Given this list of marker genes APOC2, DPP4, PDCD1LG2, DAPL1, IL10RA, PRICKLE2, SH3RF3, SERPINB9, MMP1, SATB2, WFDC21P, ADAMTS12, PDPN, CSMD1, GLT8D2, INHBA, CDKN1A, MEIS3, C1orf162, TCIM, DLC1, FILIP1L, CSF3R, APOC1, KLHL6 (kelch like family member 6), IGHV5-51, CHN2, PRELP, DIO2, C2CD4B (NCBI Gene Id 388125), NRROS, CPED1, SERPINE1, FPR1, LCP2, SDS (NCBI Gene Id 10993), ENOX1, ZFP36, NRP1, HLA-DQA2, AMIGO2, BTK, PDE1A, MEDAG, CD300E, MGP, C11orf96, CASP1, GALNT5, OLFM4, ABCA8, HTR2B, EPHA3, IGHG4, C5AR1, GATA6, MAGI2-AS3, SMOC2 (NCBI Gene Id 64094), AFF3, CD302, ACVRL1, AXL, HNMT, PALLD, DPYD, SAA2-SAA4, PTPRN2, CALD1 (NCBI Gene Id 800), PMP22 (NCBI Gene Id 5376), FAM13C, CXCR6, TRABD2A, PLAUR, CCL20 (NCBI Gene Id 6364), SCN9A, PIK3CG, VCAM1, VSIG4, TNFAIP8, KYNU, HOPX, DCLK1, GIMAP1, EEF1B2P6, TRPV2, NLRC4 (NLR family CARD domain containing 4), CCL2, NOD2, LAPTM5, CYP1B1, ADAMDEC1, ICAM4-AS1, TSHZ2, SBSPON, WNT5B, IGFBP7, ANPEP, IGLV1-40, IGHV3-48, SULF1, ZFHX4, HHIPL1, LGALS9, BTN3A3, COLEC12, SCARF1, FOXF2, SMIM3, EPS8, IGLJ2, CYTH4 (NCBI Gene Id 29776), EPSTI1, ITGA2, NAAA, RPL18AP3, EPYC, IGKV3-20, ESAM, IL6, CYP7B1, PSMB9, PTPN7, FBXO32, PLA2G4C, IGHV4-59, C1QA, KIF17, FLI1 (Fli-1 proto-oncogene, ETS transcription factor), RGS16, GGT5, ANKRD44, IGLV1-44 (immunoglobulin lambda variable 1-44), FCGR2A, STAB1, RHOBTB3, FST, SLFN11, DCHS2, SLC31A2, COL14A1, ABCC3, ARHGAP24, LST1, PPP2R2C, ARHGAP18, IGKV1-16, CORO1A, HTRA3 (HtrA serine peptidase 3), RGS1, ANKRD22, SLITRK2, HCST, ITGBL1, CLEC2B, SYPL2, GABRB3, ATP10D (ATPase phospholipid transporting 10D (putative)), PAPSS2, CLIC2, TPSAB1, IL18, HCK, TIPARP (NCBI Gene Id 25976), CERKL, CCN4, CPE, CLIC4, CTSL, PAIP1P2, COL5A1, RAB3IL1, CX3CR1, CA2, APCDD1, LYVE1, VNN2, VSTM4, LRRC8C, MS4A7, ELL2, RPS3AP6, NUDT10, SQOR, PHLDA1, KANK3, IGKJ2, IL2RA, COX7A1, LSP1, PTPN22, VWC2, TENM3, OSMR (NCBI Gene Id 9180), TMEM273, DCHS1, CELF2, EIF5A2, PDE2A, ENAM (NCBI Gene Id 200), SELENOM, ELFN1, ACTA2, ENPP1, IGLV3-10, RIMBP2, SIGLEC9, IL2RG, PLEKHO2, CD200, MCC, PDE4B, RAC1P2, MFAP4, ARL15, HLA-DPB1, FAM83B, TIE1, RPL15P3, MN1, NR4A3 (NCBI Gene Id 8013), GPR132, GIMAP7, NCF4, LRRK2, HMOX1, HOXC6, TNFAIP3, PIEZO2 (NCBI Gene Id 63896), ADH1B (alcohol dehydrogenase 1B (class I), beta polypeptide), FN1, SPRED1 (sprouty related EVH1 domain containing 1), APOC4-APOC2, SPATA18, MEG3, CYTOR, ABI3BP, TMOD2, CD93, HSPA7, IGHG1, CSTA, COL1A2, TSPAN8, CLDN5, COL8A1, TAGAP, GPRASP1, LRRC32, COL6A3, PLS3, MOXD1, TDO2, TMEM86A (NCBI Gene Id 144110), DPP7, ADGRA2, CFI, TLR8, BIN2, CCR2, GPR65, ETV1, PCYT1B, BCL6B, PLPP4, EPAS1, CXCL13, FKBP14, GRK3, PDLIM5, SLC18A2, HLA-J, FABP4, DPYSL3, IGLJ1, PPP3CC, CPNE5, PAG1, FAM81B, PLAGL1, SLC11A1, PPM1L, P2RY1 (NCBI Gene Id 90963), STOM (NCBI Gene Id 2040), ADGRB3, CAV1, TCF4, EMILIN2, FIBIN, CST7, B3GNT9, CXCL10, CRISPLD2, SLC24A3, SERPINE2, JAK3, CISH, TIMP1, SASH3, SLITRK5, HOXC12, SHE, KCTD12, PDGFRL, ERG, GAS6-AS1, SCARF2, COL6A2, COMP, IGLV1-47, VCAN, SKAP2, HMCN1 (hemicentin 1), HLA-DPB2, DTNA, SLC40A1, TNFRSF8, ALPK2, TIMP3, CCDC69, RRAS, NIPAL2, RHOH, FPR3, LRRN4CL (LRRN4 C-terminal like), CYRIA, CD163L1, HLA-DRA, ARHGAP9, GPNMB, ELOVL4, SCN1B, SYNE1 (NCBI Gene Id 85448), PAMR1 (NCBI Gene Id 25891), COL4A2-AS1, DOCK2, THBD, SNRPA1-DT, TMEM215, PEAR1, IGHV2-26, CSMD2, SERPINI1, SATB1, SPON2 (spondin 2), TIGIT, SLC1A1, BEND4, JUNB, PLOD2, RHOJ, COL5A2, SPARC, SLC2A5 (solute carrier family 2 member 5), HLA-DQB1-AS1, IL32, TACC1, RUNX2, EMCN, SIRPB1, IRAG1, IRS1, CDC42EP5, PDE10A (phosphodiesterase 10A), ELN-AS1, LYSMD2, IGHV1-24, FYB1, HLA-K, HBEGF, NTM, GREM1, RARRES1, GUCY1A1, PI15, CYBB, ADAMTS2, MRAP2, MLKL, CCDC80, CRACR2A, TREM2, SAMD5, DUSP1, DKK2, SEPTIN7P3, AKR1C3, TBX3, THY1, HCG4B, MCTP1, NID2, PLA2G7, ELMO1, ADAM12, CD44, S100A8, NAP1L3, MIAT, PCOLCE-AS1, FXYD5, MEIS2, GTSF1, EBI3, FRMD6, CAVIN3, GSTM5, LAMP5, DIPK2B, CACNA2D4, VSNL1, UBD, HLA-DMA, IGSF6, PEG3, ST8SIA4, FCN1, KCNA5, SFRP4, CD300A, C8orf88, GPR84-AS1, ROBO2 (NCBI Gene Id 90370), IKZF1, STAMBPL1, CFB, IGLV3-21, CIMAP1B, OLFML2B, MMP9, PTN, HLA-DRB5, DERL3, LAG3 (lymphocyte activating 3), SFRP1, ACTG2, ADAMTS7, IGLV2-14, SLC16A6, HOXA-AS2, FTLP3, STX11, IGKV1-9, RTN4RL2, NECAB1, NPTX2, HLA-DQB1, OLFM1, TNFRSF11A, SERPINF1, LOXL2, RASGRP3, CD180, SLC16A14, PRDM6, GPR137B, RPL9P7, STARD8, MATN3, CACNA1H, C2CD4C, LAMA2, SAA2, P2RX7, JAZF1, FGD2, PELATON, DACT1, DPYSL4, CDH13 (cadherin 13), SNCA, GZMK, MT1G, JCAD, ITGA5, KCNA6, NLRP3, COL5A3, HEYL, IGHG3, GIMAP8, SNX20, VIT, CD248, CLIC6, STARD5, FLT3LG, PLCXD3, DOCK10, SRPX2, MMP2 (NCBI Gene Id 4313), LILRB4, NDN, HLA-DMB, SLC7A7, RARRES2, PLSCR4, DCN, CXCL8, CARD16, PRRX1, TBX18 (NCBI Gene Id 9096), ABCA9, IGHV3-53, SECTM1, GALNT15, FCGR3A (NCBI Gene Id 2214), GNG11, PLAT, CCDC85A, RPL10P16 (ribosomal protein L10 pseudogene 16), IL4R, ALOX5, FGR, FERMT3, CD8A, HSPA12B (heat shock protein family A (Hsp70) member 12B), FGL2, PTPRB, IL15, MAP1B, TMEM150C, LINC00511, CR1, C2, MFNG (NCBI Gene Id 4242), ADAM8 (NCBI Gene Id 101), COL6A1, PTPRC, MICU3, IGHV4-39, FOXL1, RPL3P4, ACKR1, MYO1G, STK17B, SYCE1, CBLN2, IGKJ5, RPL5P1, MRC2, GDF6, PAPPA, CNRIP1, IL18R1, PDLIM3, COL3A1, IGLV3-25, DOCK4, HLA-DQB2, LIPA, SPOCK1, SERPINA1 (serpin family A member 1), SAT1, NEFH, MSC-AS1, NRXN2, GRAP, IL1RN, CHST7, ALKAL2, ADAMTSL2, LINC01018, LACC1, CCBE1, RPL17P7, LDAF1, MMP11, CTSS, CYS1, RPL39P3, RAMP3, SDC2, JAK2, EDN3, ASPN, CAVIN2, MPP1 (NCBI Gene Id 4354), FOXF1, OSBPL6, ARHGEF6, IGHGP, HAVCR2, MFRP, DGKI, FLRT2, TIMP2, MT2A, UPP1, SLC16A7, SIGLEC7, RPS3AP26, ERAP2, SLC12A5-AS1, GALNT18 (polypeptide N-acetylgalactosaminyltransferase 18), CXCL9, SRGN, LRRC25, RPL26P36, CILP, SPHK1, NKX3-1, CNTN4, DOK2, PLXDC1, ARHGAP10, PTGDS, PPP2R2B, SGK1, PYCARD-AS1, GHR, HLA-H, OSM, CHRNA1, IGHV3-7, FCGR2C, FMO2, ARHGAP25, VCAN-AS1, LRP1, MTUS1, ANTXR2, ST3GAL5, ARHGEF15, SLC37A2, RPL13AP5 (NCBI Gene Id 728658), CLEC11A, FAP, CMAHP, IGFBP4, IRF1, CPNE8, PSD3, TARID, HLA-DRB6, RBP7, RASSF2, ALOX5AP, CASC15, CD247, DPYSL2, NT5E, CD163, LXN, NCKAP1L, NR5A2, CSGALNACT1, TPST2, ATP8A2, VAMP5, SERPINA3, NLRP1, IFIT2, TSHZ3, PRDM1, CXCL14, CAVIN1, GASK1B, FBXL7, CH25H, NLRC5, ENG, SLC43A1, DPT, LHX9, EDA2R (NCBI Gene Id 60401), ANXA6, APOE, RASAL3, NNMT, THSD7A, RORA, PLEK, LRRC15, ITPR2, OLFML3, CCL19, NCF2, NR3C1, STARD13, PRKD1, RHOB, PLA2R1, COL1A1, GATA4, ADM (adrenomedullin), ENPP2, FTH1P10, PLVAP, CARD6, ABLIM3, MSRB3, GUCY1A2, SUCNR1, NR1H4, LDLRAD4, SOX18, PHLDB2, NRK, MPEG1, GPSM3, GSPT2, TNFRSF4, TCF21, TBX15, LUM, CD209, MZB1, IGKV3D-15, C4B-AS1, DNAJB4, CD14, CHIT1, HEPH, JAML, PRF1, IFI30, PLA2G2D, HLA-F, IL33, SIRPB2, LOXL2-AS1, UBE2QL1, KCNJ2, NRP2, C1QTNF7, TRPS1, SLIT2, ACSL5, KCNMB1, POSTN, NDNF, GNB4, WDFY4, CMKLR2, HLA-DRB1, RPS13P2 (NCBI Gene Id 91505), ITGB2 (integrin subunit beta 2), DHRS3, MXRA8, MS4A4A, TRIM47, EDNRA, FAT4, PIK3R5, HIC1, GRK5, CXCL1, CASS4, NFASC (neurofascin), SH3BGRL, CASP10, SELENOP, RPL7AP6, ASTN1 (astrotactin 1), MNDA, FEZ1, LPXN, TNFRSF9, AK5, WSCD1, PLD1, S1PR1, HAS2, ITGAL, SELL, SLPI, RAB8B, ARHGAP31, NUDT11, HYCC1, CEACAM7, CLEC4A, DHRS9, ADGRF5 (adhesion G protein-coupled receptor F5), PIK3AP1, C3, PDGFRB, PTPN5, TNFRSF1B, IGHV1-2, MAP1LC3A, ITGA11, PRRG3 (proline rich and Gla domain 3), CADPS, SLITRK4, GSDMC, LYZ, GBP2, MMP19, FCER1G, IRF8, KCND3, PON3, PDZD4, CCN1, GPR78, SIGLEC1, LIN7A, RCAN2, PLA2G2A, CXCL17, RTN1 (NCBI Gene Id 8108), ARHGAP20, BMP6, PPP1R2P4, SVEP1, KLHDC7B, ACP5, GPC6, B2M (NCBI Gene Id 567), PDZRN4, CXCL2, PARM1, HS3ST3B1, ACAN, DYNLT3, CD48, RERG, WNT5A (Wnt family member 5A), IGHA2, MEF2C, MEGF10, TM6SF1, MARCHF3, MT-TM, SCN7A, PRDM8, CXCL12, PRKCB, TREM1, RAMP1, MIR100HG, PROCR, F2R, LILRB2, ARRDC3, P2RY8, FSTL1, CNTN1, NALF1, SIRPA, SERPING1, EPB41L3, OGN, HLA-B, KCNS3, EGR2, CD68, NME5, IGKJ4, APOD, CSF1R, SLC1A6, RBPMS-AS1, KLF2, TNFAIP8L3, SFXN3, ODAD2, F5, IGKV1-5, DOCK8, RAB6C, HS3ST3A1, IGKJ3, APLNR, SOCS3, PRCD, HLX, PLCL1, RPL21P16, APOL1, GPM6A, ANGPTL2, BGN, PLAU, BEND6 (BEN domain containing 6), ERO1B, BTBD19, RGCC, TNFSF8, KCND2, C1QC, ALDH1A3-AS1, THSD1, PSTPIP1, SSTR1, BCHE, CCND2, FGF13, LGALS1, FTH1P2, TBC1D4, PRSS35, FAS, TNFAIP6, ECM2, DOK6, PCED1B-AS1, SSC5D, VWA1 (von Willebrand factor A domain containing 1), INPP4B, PPP1R16B, FMO3, GAS6, HP, CLEC14A, HLA-DQA1, IL7, RAB42, CD86, LINC01614, RGL1, KLF6, NTS, RIPOR2, FCHO2, SNAP25, SCIMP, LILRB1, SH2B3, TMEM119, C4A-AS1, ADA2, SLC7A2, ENSG00000240207, LPAR6, RASGRF2, MAN2A1, TAP1, PCDH12, SPP1, RFTN2, KCNK6, RUNX1, DIRAS3, TMEM204, LAT2, GPR85, MT1E, HSPB8, HS6ST2, HBA1, THSD7B, CD4, ROBO4, SLC2A13, FRMD3, NKD2, C1S, SLC9A9, DSEL, NBL1, ABCB1, EMILIN1, TYMP, CSPG4, COL4A1, HGF, LRCH2 (leucine rich repeats and calponin homology domain containing 2), HK3, ADAMTS4, ENSG00000251095, GMFG (NCBI Gene Id 9535), CHI3L1, PSMB8-AS1, CCR1, LINC01094, XYLT1, CMKLR1, ARHGAP15, IGLV1-51, PLXNC1, DNAJC12, IGHJ6, ADCY4, HAND2, FAM171B, KCNT2, NRP2-AS1, CACYBPP2, MAN1A1, LHFPL6, RAC2, LYPLAL1, IGHV1-69, ATP2A3, MDFIC, NTRK2, SEPTIN4, LOX, ITGB1P1, AGAP2-AS1, ADGRE2, OMD, PROS1, PLN, GFRA1, AOX1, ITGAX, RAB27B, CACNA1G, IGHV1-18 (immunoglobulin heavy variable 1-18), MORF4L1P1, RBMS3, G0S2, OR2I1P (NCBI Gene Id 81065), DRAM1, IGKV4-1, ETS1, APOBEC3G, LY86, PTGES3P3, FOLR2, CPZ, APBB1IP, TLL1, CDH5, C7, PLD4, DKK3, CILP2, EMB, FOS, DLK1, TFPI, LY96, SPART, ENPEP, CCN2 (cellular communication network factor 2), CDO1, CLEC7A, KCNAB2, PDIA3P2, HEY1, SEMA5B, C1QTNF5, AMPH, SELP, FMO1, RASGRP2, ESR1, MSN, EOGT, ADAM23, FCGR1A, S100A9 (S100 calcium binding protein A9), C9, IGKV3D-20, ISLR, THBS1, RGS5, GPR84, IL2RB, OSCAR, CDK14, CD79A, ITGA1, H19, THBS2, SP140, TLR7, STEAP4, IGHV2-5, DEPTOR, ZBTB16, CNR1, GNG4, TRBC2, SNAI2, LYL1, CHI3L2, TMEM47, MT1M, AOAH (acyloxyacyl hydrolase), CCL8, CYGB, BMP4, APOL3, TTYH2, GATM (NCBI Gene Id 65211), LAMB1, PLCB2, GPR176, MAF, CD3E, PDE7B, CDC20B, QPCT, ISM1, FAM89A, PTGIS, ESM1, IGHM, NPL, MAPRE2, A4GALT, DCHS1-AS1, ZFPM2, ASPH, SLC38A5, MYCT1, SOCS2, EFEMP1, ME1, VWF, LILRB3, SCIN, CD84, IGLC3, CYTIP, TNFSF10, ARSL, NKG7, MMP13, TNFAIP8L2, CYBRD1, SIGLEC10, CMTM3, CAMK2D, GPR34, CYP27A1, MYO1F, RPS27AP11, GIMAP5, TMEM98, FNDC4, SLC46A3, SLA, EXOC3L1, PLK3, TWF1P1, SP6, PTPRE, APOL4, SAA1, BCL2A1, PODNL1, COL11A1, P3H3, VGLL3, ZCCHC24, FBLN5, ITGB6, RNASE6, TFEC, CACNA2D1, VNN1, FKBP7, ITGA4, FAM78A, TMEM26, VWFP1, BHLHE41, TLR3 (toll like receptor 3), ADAM22, WAS, SLCO2B1, CHST2, TYROBP, IGLV6-57, HHIP, PLPPR3, TMEM200A, CD36, TRIL, IL16, ALDH1A3, SGCD, ELN, DUSP2, TMEM154, LMO2, CCL11, ATP8B4, GSDME, CSF2RB, APOBR, TGFB1I1, PCOLCE, IGLC2, EFCC1, EGR1, CTSK, FGD5, VAT1L, PWWP3B, PDK4, ABHD3, GZMA, ITIH3, RAP1BL, CREB3L1, RCSD1, CLMAT3, ITGA8, A2M-AS1, VIM-AS1, IGHV4-31, IFIT3, SLC4A4, GULP1, VWA5A (von Willebrand factor A domain containing 5A), TMEM158 (NCBI Gene Id 25907), SPI1, TMEM255A (NCBI Gene Id 55026), COPZ2, DDR2 (discoidin domain receptor tyrosine kinase 2), SLCO2A1, BNC1, VSIR, GGTA1, IGKC, LILRA6, ADAP2, TSPAN5, PNMA2, GNA15, ITM2B, FTL, GYPC, SCUBE1, RCN3, ADAMTS10, LRRC4B, PCED1B, SERPINB8, HCP5, RAMP2, RASA3, STAT4, IGLV5-45 (immunoglobulin lambda variable 5-45), SEMA6B, COL8A2, HLA-DOA, PRKACB, PTGS2, MAPK11, KITLG, SH2D3C, LGALS2, SPIB, DUSP5, TMEM176B, EDIL3, RAB31 (RAB31, member RAS oncogene family), LAIR1, ARX, NR5A1, AQP9, PLAAT4, AMPD3, UBA7, PODN, GPR183, CDH2, SYNPO2, GLRX, C1QTNF1, SEPTIN11, RGS4, CTBS, CALHM6, C1R, TNFRSF11B, CXCL3, OLFML1, APELA, SLC2A3, CSF2RA, GPR68, C12orf60, APOL6, TGFBI, IGLL5, SCUBE2, LCN2 (NCBI Gene Id 3934), ADAMTSL4, GJB6, TCEAL7, BTF3L4P2, CHST11, NAMPTP1, TLR2, RPS3AP21, CHRD, EMP3, TNFRSF14, PREX2, TG, ANTXR1, C3orf70, WDR17, GPRIN3, NOTCH4, SNX10, RPL17P36, BASP1, RPL5P4, COL2A1, MMRN2, MMRN1, DOCK11, ENSG00000233968, FHOD3, ADCYAP1R1 (NCBI Gene Id 117), WTAPP1, HAPLN1, ABCA6, SIDT1, IFFO1, NEXN, AEBP1, IL3RA, PCDH17, ITPR1, IGLV2-23, TRABD2B, TGFA, PDGFD, PYCARD (PYD and CARD domain containing), MRGPRF, ABCG2, CLVS1, HTRA1, SMARCA2, CAMK4, LPAR5, BICC1, CORIN, IGHV3-21, WFDC1, CFH, RPL41P1, CALHM5, SOD3, SULT1C4, TPSB2, LDB2, RARB, MYH11, PYGO1, NPR3, TLR1, GIMAP4, CADM3-AS1, RGS7BP, ARHGAP30, ITGAM, IRAK3, MME, KCNK3, CHSY3, SPN, RRAGD, TPBG, DEPP1, CCR5, IGDCC4, RPL26P19, LITATS1, POGLUT2, EVI2B, HMGN2P5, GRIK3, FAM43A, SFMBT2, EHD2, IL7R, INMT, IGHV3-66, ATRNL1, PCK1, IGKV3-11, ELOVL2, MMP14, COL21A1, NFATC2, ANOS1, CTHRC1, ECSCR, CD53, SGPP1 (sphingosine-1-phosphate phosphatase 1), HSD11B1, CD34, ENSG00000225032, PDZK1IP1, RPL13P12, LINC01929, CNTNAP1, IGKV3D-11, SPARCL1, GADD45B, IGHV1-3, CCN5, EBF1, TAGLN2P1, HBB, ADORA2A, TAGLN, NIBAN1, PTEN, SNCAIP, IGHV3-11, SLC47A1, CCDC68, PID1, SHC2, DNM3OS, HCLS1, HEG1, FGF7, EVI2A, TSHZ1, HLA-C, MS4A6A, GDNF, CPA3, TRPC6, FZD1, NEGR1, AQP1, SFRP2, ITM2A (NCBI Gene Id 9452), TBXAS1 (thromboxane A synthase 1), C3AR1, RECK, SNHG28, CD96, LMOD1, OLR1, KLHDC1, PCOLCE2 (NCBI Gene Id 26577), IGHV3-23, ICAM5, TM4SF18, GAB3, STING1, IGLC1 (NCBI Gene Id 3537, immunoglobulin lambda constant 1), CORO1A-AS1, ZEB2, JCHAIN, IGKV3-15, BCL11B, EAF2, OSTM1, ST8SIA1, TRIM22, NUPR1, GASK1B-AS1 (GASK1B antisense RNA 1), IFI16, SAMD9L, ADGRL4, PARVG, INPP5D, CFD, SLC16A2, C15orf48, JAM2, C4B, GJA1, CLMP, CD74, FAM20A, BCL2, MAN1C1, PAEP, SHOX2, APOC4, IGHV1-46, C3orf80, HLA-A, GAS6-DT, IGFBP7-AS1, PLPPR4, CNTN3, RUNX1T1, SERPINB1, VIM, TLE4, JAM3, CALB2, FGF1, CADM3, HSD17B11, DLL4, SYNPO, LINC01140, EDNRB, CLEC10A, GLI1, TNFSF13B, PTPRO, CD28, KLRG1, CPP, LZTS1 (leucine zipper tumor suppressor 1), SERPINB2, COL12A1, EGR3, FCMR, PTGER2, GBP4, DAB2, ZEB1, LTBP2, IDO1, C1QB, SELPLG (NCBI Gene Id 6404), NLGN4X, CD40, NID1, CLEC4E (C-type lectin domain family 4 member E), MT1H, ARSI, GLIPR2, AGAP2 (ArfGAP with GTPase domain, ankyrin repeat and PH domain 2), IGHG2, TNFRSF18, FHL2, GIMAP2, CLEC5A, ABCB4, ZNF365, RPL12P4, HECW2, IGLV3-1, TEK, IGKJ1, OGFRL1, SULF2, C4A, CACNA1C, DYNC1I2P1, F13A1, KCNK13, LRRN3, HCAR2, IL21R, GJB2, RGS2, RPS23P8, SAMSN1, PGR, CP, GAS1, KLHL4, LAMA4, CHN1, ECM1, MSR1, IGKV1-12, PSMB10, SLAMF8, COPDA1, GFPT2, HOXD10, SETD7, CD38, CCL21, PDGFRA, AHR (NCBI Gene Id 196), GPR4, IFNGR1, FLT4, KCNE4, NFAM1, JPH4, LRRC55 (leucine rich repeat containing 55), CD52, ITK, SLAMF7, FCGR3B, TLR6, EVA1C, LPL, KCNJ8, AFAP1L1, C10orf55, FCGR2B (NCBI Gene Id 2213), A2M, CD2, CDC42P6, SHISA2, PTHLH, SMPDL3A, C16orf89, WASF3, AKT3, TLR4, RPS27L, MYOCD, TWIST1, NPY1R, KLF9, NLRC3, PITX2, PROX1, NDUFB4P12, CDH11, HLF, MGLL, SCG2, BMERB1, STAR, C1QTNF6, BMP2, FNDC1, FBN1, IGHV3-15, RASSF4, IRAG2, PDE1B, IGHA1, IGKV1-17, UNC5C, ACTA2-AS1, HBA2, MAGEL2, ABI3, AIF1, COL6A6, POU2F2, STEAP2, NAV3, HLA-E, FKBP5, IL1B, GAL3ST4, IGLV2-11, NR4A1AS, GPX8, PDE3B, FLT1, HS3ST1, CHGB, CALCRL, CCDC102B, TAFA2, RASIP1, SYDE1, AOC3, TMIGD3, NR4A1, MAP3K4-AS1, MSC, COL10A1, HLA-DPA1, STK32B, GNG2, GIMAP6, CCDC152, LCP1, IGHV3-33, POU2AF1, PDE5A, RUBCNL, IL6ST, EIF2S3B, KDR, PKIA, ADAMTSL1 (ADAMTS like 1), RPL7P1, MAFF, MMP16, CEBPD, MARCO, MARCHF1, LHFPL2, LCK, RPS2P5, CXCL11, DACT3, CLDN11, GEM, MAOB, ITPRIP, COL15A1, ZNF469, LAMP5-AS1, SLC16A3, SRPX, FOSB, PKIB, LRRC17, PTAFR, BIRC3, PXDNL, PCSK6, IGF1, ANGPT2, THY1-AS1, ARHGDIB, BTN3A2, CD1E, CD44-AS1, GBP5, CD69, IL15RA, ATP1B2, TESC, WIPF1, ZNF521, SCG5 (NCBI Gene Id 6447), TMEM176A, CD274, COL16A1, PTGER3, PRKG1, RFTN1, IGLV3-19, FKBP1C, IGHV3-74, TRPA1, SEMA3C, MANEA, ICAM1, here is a description of the gene set: species: Homo sapiens Human Gene Set: LIU_OVARIAN_CANCER_TUMORS_AND_XENOGRAFTS_XDGS_DN from publication Liu Y, Chanana P, Davila JI, Hou X, Zanfagnin V, McGehee CD, Goode EL, Polley EC, Haluska P, Weroha SJ, Wang C (PMID 31004097) Genes differentially expressed between PDX and donor tumor samples from nine ovarian cancer patients. A bioinformatics pipeline to separate donor tumor and mouse stroma transcriptome profiles was devised and tested. To examine the molecular fidelity of PDX versus donor tumors, the authors compared mRNA differences between paired PDX-donor tumors from nine ovarian cancer patients.